The following is a description of a gene set: Human Gene Set: HP_BILATERAL_TONIC_CLONIC_SEIZURE studied in species Homo sapiens Bilateral tonic-clonic seizure A bilateral tonic-clonic seizure is a seizure defined by a tonic (bilateral increased tone, lasting seconds to minutes) and then a clonic (bilateral sustained rhythmic jerking) phase., and this is the list of marker genes: SLC12A5, MT-TC, PIGH, ATP6AP2, HCN2, ACBD6, KMT2D, STAT3, STX1B, MECP2 (NCBI Gene Id 8274), GCK, MT-TH, NUP214, YIPF5, ZNF142, ALDH7A1, COX8A, HEXB, CLTCL1, AP2M1, NPRL3 (NPR3 like, GATOR1 complex subunit), ADAM22, AGO1, ADGRG1, ATP6V0A1, GRIA3, CLCN3, ATP1A2, FRRS1L, ATP5F1D, WDR26, GRM7, MICAL1, PPIL1, NDUFS4, TRPM3, FAR1, SCN2A, DNAJC5 (NCBI Gene Id 80331), COL4A2, DPYSL5, SLC25A19, TUBA1A, CRELD1, CHMP2B, SLC2A1, PIGS, CEP85L, TSEN2, CRADD, PIDD1, NSD1, CTCF, MAPK10, NEXMIF, MT-ND3, PUM1, GJA5 (gap junction protein alpha 5), THOC2, CUX2, GRIA2, ACY1, PPP3CA, CLN8, DHX16, CAMK2B, CHRNA4, NDUFA1, GET4 (guided entry of tail-anchored proteins factor 4), PPP2CA, ATP6V1A (NCBI Gene Id 523), SCN1A, INS, CLPB, KCNN2, IQSEC2, CACNB4, PLCH1, CDKL5, PIGV, GABRB3, NPRL2, KCNJ11, SLC1A2, GBA1, NBEA, IER3IP1, PSPH, PIGF, TSPOAP1, TBCD, OGDH, ACTL6B, MT-CO3, CHRNA2, MAPT, DOHH, AFF3, FZR1, GABRG2, PIGY, BUB1B (NCBI Gene Id 701), PAK3, CARS2, TP53, AFG3L2, PIGO, ARFGEF1, MACF1, PIGL, ACADVL, SV2A, RELN, LGI4, TRIM8, LMAN2L, EFHC1, SLC25A22, CILK1, ABCC8, CHD2, KCNC1, KPTN, KCNQ3, DNM1L, IREB2, HTRA1, EPM2A, SP110 (NCBI Gene Id 3436), KCNT1, DEPDC5, MTHFR, CIC, LMNB2, CSTB, UBE3A, KCNC2, KCNB1, PTEN, AFG2B, ATRX, KCTD7, CTSF, WDR62, SYNJ1, APC2 (APC regulator of WNT signaling pathway 2), NDUFAF4, MTFMT, GNAI1, GRN, KCNH5 (potassium voltage-gated channel subfamily H member 5), MT-TS2, D2HGDH (NCBI Gene Id 728294), MOCS2, SLC4A10, MT-CYB, GRIK2, CNTN2, COQ5 (NCBI Gene Id 84274), POGZ, HERC1, TUBA8 (tubulin alpha 8), GABRA5, CAMTA1, TECPR2, NIPA1, CACNA1H, COQ4, SMC1A, GRIN2B, GRIN2A, PDSS2, PACS2, SCN9A, ACADM, AKT2, GPHN (gephyrin), CHRNB2, BCKDK, NEUROD2, GNB1, FBXL4, PURA, SUOX, EEF1A2, EXOC8, GLYCTK, GABRD, CCDC88A, ADGRV1, NDUFA2, WARS1, PPFIBP1 (PPFIA binding protein 1), TBC1D24, MT-TW, HID1, AHDC1, TSEN15, SLC1A4 (NCBI Gene Id 6509), SCN3A, AP3D1, DENND5A, DYRK1A, PIGT, DEAF1, EIF4A2, YEATS2, PSAP, CERT1, CACNA1B, GABRA3, MT-TK, VPS53, DOCK7, GNAO1, LAMC3, SLC32A1, KCNMA1, SETD1B, STXBP1, FIG4, STUB1, PIGQ, NUS1, SARDH, PCDH19, DMXL2, TXN2, FBXO28, LBR, TANGO2, ADPRS, PGAP3, PEX5, TSFM, SCN1B, VCP, VAMP2, DPH5, PIGW, MT-ATP6, PLPBP, WAC, GALT, RAB18, GTPBP2, CDC40, SETD1A, HCN1, CLN3, SLC1A3, SZT2, SAMD12, ARX, MT-TF, ESAM, ATP6V0C, PGAP2, GABBR2, CACNA1A, SLC7A6OS, GYS1, ARNT2 (NCBI Gene Id 9915), UBE4A, PGAP1, MT-TQ, TRAPPC11, GOSR2, PNKP, JRK, FGFR1, RNF13, METTL23, TREM2, DNM1, NR4A2, SLC9A6, RFX7, NDUFA4, KDM6A, PRPS1, MT-ND1, ZMYND11, TMEM106B, DHDDS, DDX59, GPT2, KCNK4, EHMT1, MT-ND4, KCNA1, PCYT2, ACO2, FGF12, CAMK2A, MT-CO1, CPA6, SLC6A5, ATP1A3, PDHA1, TMX2, ST3GAL3 (ST3 beta-galactoside alpha-2,3-sialyltransferase 3), NARS1, RAP1GDS1, PUS3, ARHGEF9, ALDH5A1, HSD17B4, SYNGAP1, SARS1, FA2H, CPLX1, STARD7, PIGA, MT-ND2, PRRT2 (proline rich transmembrane protein 2), SLC22A5, DOLK, RNH1, NEK1, RPL10, TMEM94, LONP1, MT-TV, ZNF526, ASAH1, EZH2, SRPX2, POLG, PDX1, CASK, KCNQ2, SPTAN1, ADORA2A, HNRNPC, GAL, SQSTM1, LGI1, GAD1, GABRA1, MT-ND5, TSEN34, PIGP, HHAT, SLC6A1, ASPA, CLN6, MT-ND6, CLCN4, TRAPPC6B, ST3GAL5, HADHB, GRIN1, HNRNPU, SEPSECS, CTLA4, FGF13, AFG2A, VPS13A, GAMT, SIK1, RORB, CRH, TSEN54, KIF4A, GLRA2, ATP6V1B2, CERS1, LNPK (lunapark, ER junction formation factor), NHLRC1, GPAA1, GJA8, MAST3, HACE1 (HECT domain and ankyrin repeat containing E3 ubiquitin protein ligase 1), CNTNAP2, PHGDH, CASR, SLC38A3, CLCN2, SATB2, ERCC6, UFSP2, ROGDI (NCBI Gene Id 79641), NAA10, WWOX, MARCHF6, CACNA1D, CABP4, PLCB1, TEFM (NCBI Gene Id 79736), PSEN1, SCN8A, MT-CO2 (NCBI Gene Id 4513), GLUL, PYCR2, MT-TL1, BTD, TBCK (NCBI Gene Id 93627, TBC1 domain containing kinase), PIGG